Given this list of marker genes H2-Eb1, Tgm2, Malt1, Il18, Arid2, Agr2, Hacd1, Cd1d1, Epha7 (Eph receptor A7), Has2, Pycard, Smarcd2, C2cd4a, Src, Tnc, Rc3h2, Xcl1, Zfp608, Cd86, Sema3e, Pdgfb, Iqgap1, Nlrp3, Trpv4, Slc7a1, Glmn, Gpam (NCBI Gene Id 14732), Prex1, Ccl2, Dusp10, Ctla4, Icos, Ihh, Dscam, Kitl, Itga3, Tnf, Gstp1, Bad, H2-Ob, Nfkbiz, Serpine1, Cx3cl1, Hspd1, Dnm2, Ap1ar, Adamts18, Dll1, Nkap, Kng1, Dbn1, Il1rl2, Il3, Spaca7, Chst2, Cd3e, Plxnc1, Selenok, Cd4, Itpkb, Jag1 (jagged 1), Ptpn23, Cd44, Zc3h12d, Wnt1, Ptpn1, Ptpn11, Htr2a, Cebpb (NCBI Gene Id 18031), Cbfb, Plxnb1, Foxo3, Plxnb2, Tgfb2 (NCBI Gene Id 98738), Slk, Clasp1, Rin2, Igfbp2, Myadm, Cd209e, Tesc, Spta1 (NCBI Gene Id 98361), Col8a1, Mir326, Pag1, Npy2r, Fbxo38, Mad2l2, Ctsg, Hspg2, Cdkn2a, Ccn1, Itgal, Mia3, Ccl21f, Srf, Fcho1, Ceacam1, Actg1, Tescl, Prkcq, Rbpj, Peli1, Tnxb, Vav3, Sema4d, Il6, Kdr, Ccl21e, Cxcr4, Taok2, Acp5, H2-Eb2, Cspg5, Meltf, Dysf, Cldn7, Edil3, Spi1, Prkcd, Efnb2, Atp5f1b, Muc21, Tmx1, Smarcd3, Cask, Tsc2, Rnase10, Kif14, Vps33b, Lilrb4a, Sema5a, Nf2, Shh, Apod, Il23a, Fgg, Apoa1, Rras, Map2k1, Cd27, Cyrib, Ccl21a, Hlx, Pik3r2, Pik3cb, Lrrc32, Lrfn3, Dsg2, Fadd, Angpt1, St3gal4, Lamc1, Adam9, Epha8, Ephb2, Atm, Fbln2, Shb, Jag2, Dhps, Fn1, Btnl2, Pdcd1, Tnr, Il21, Il12a, Coro1c, Casp3, Cdh1, Dab1, Lama4, Sox13, Bag4, Col16a1 (collagen, type XVI, alpha 1), Ank3, Plxnb3, Nat8f2, Akna, C2cd4b, Men1, Foxf1, H2-Aa, Capn1, Kifap3, Tespa1, Nat8f5, Ccl25, Rps3, Gcnt1, Smad3, Prkaa1, Npnt, Plet1, Itch, Csf1, Phldb2, Ppp1cb, Sema6a, Carmil2, Utrn, Clec4g, Rasa1, Emp2, Traf6, Flot1, Rac3, Cd24a, Spock2, Adgrg1, Rela, Slfn1, Il1b, Wnt4, Notch4, Fut2, Cd80, Mdga2, Ift74, Zdhhc2, Loxl3, Stat5a, Gp1ba, Coro1a, Ambra1, Vwc2, Smad7, Nodal, Ptk2b, Abl1, Nat8, Lgals9, Mad1l1, Nfkbid, Vcam1, Cbll1, Dtx1, Col1a1, Cxcl13, Serpine2, Ceacam2, Adk, Bmp6, Tnfrsf21 (tumor necrosis factor receptor superfamily, member 21), Arl2, Prkar1a, Dag1, Rag2 (recombination activating gene 2), Piezo1, Ilk, Pde3b, Spg7, Bmi1, Actl6a, Dlg5, Nuak1, Ywhag, Srcin1, Podxl, Rac1, P4hb, Foxp3 (NCBI Gene Id 20371), Erbb2, Ufl1, Ripor2, Tnfrsf13c, Jam3, Wnt10b, Gnrh1, Mdk, B2m, Pawr, Cyth3, Zc3h8, Mmrn1, Brd2, Abi3bp, Dennd6a, Jak2, Ccl5 (NCBI Gene Id 20304), Ephb3, Havcr2, Slamf1, Cd55, Ndnf, Cd5, Icosl, Arpc2, Smoc1, Nck1, Plxnd1, Card11, Erbb3, Itgb3, Nrp1, Lgals1, Sh2b3, Swap70, Fzd7, Pnp, Efnb1, Gpr4, Smarcc1, Epha1, Ddr1, Nedd9, Vsir, Dusp3, Rag1, Cd274 (CD274 antigen), Peak1, Lamb2, Nf1, Bmp7, Ptprc, Dact2, Dapk3, Il2ra, Tigit, Tesk1, Cd55b, Ptprz1, Flna, Ptpru, Pde4d, Snai2, Fbln1, Mdga1, Ptk2, Pdpn, Nrarp, Myo1f, Tnfsf13b, Tnn, Dock8, Epo, Fes, Elane, Cd40lg, Wdpcp, Ccm2l, Cd59a, Nckap1l, Pten, Il15, Arg1, Triobp, Chrd, Bmp4, Acvrl1, Pla2g2a, Ythdf2, Rc3h1, Lyn, Ptpn2, Itgb2, Lims1, Prnp, Adam10, Defb21, Il36b, Gata3, Cd74, Celsr2, Pla2g2f, Fam107a, Il2 (NCBI Gene Id 16183), Fga, Ep300, Cd9 (NCBI Gene Id 12527), Prkcz, Angpt2, Jak3, Lpxn, Irf1, Hrg, Lims2, Plpp3, Cxcl12, Fzd4, Itga4, Socs6, Dmtn, Sdc4, Efna5, Lgals3, Dicer1, Ninj1, Muc4, Prkg1, Cfl1, Ccr2, Hoxa7, Sox12, Fermt1, Thbs1, Ptn, Stk4, Adam15, Cav1, Ido1, C1qtnf1, Smarcc2, Dusp1, Dlc1, H2-Oa, Plau, Bcar1, Pkd1, Ldb1, Coro2b, Gfus, Prdx2, Myo10, Cd244a, Ppp3ca, Mink1, Anxa1, Smarcb1, Cd83, Lgals8, Map2k5, Hsp90aa1, Rgcc, Ets1, Tjp1, Phf10, Pck1, Lag3, Itga5, Hes1, Pik3r6, H2-M3, Tyk2, Vav1, Ptprj, Ripk2, Cd6, Dab2, Ifnb1, Ptpn6, Acer2 (NCBI Gene Id 73682), Dock5, Crtam, Smarcd1, Chst4, Plaur, Itgb1, Postn, Pdcd1lg2, Cd63, Calca, Ephb4, Epha3, S100a10, Pcsk5, Zbtb7b, Prkca, Sftpd, Smarce1, Mbp, Dusp26, Hfe, Cyld, Cytip, Il7r, Ibsp, Cdh13, Skint1, Scrib, Rock1, Nfat5, B4galnt2, Igf2, Twsg1, Tbx18, Rap1gap, Sele (selectin, endothelial cell), Il7, Grem1, Il20rb, Ndfip1, Epha4, Clasp2, Cd209d, Alox15 (arachidonate 15-lipoxygenase), Epha5, Smoc2, Sash3, Emilin1, Emcn, Efnb3, Actl6b, Bmp2, Gpnmb, Nr4a3, Lep, Zfp35, Ptpra, Prkx, Il4, Lif, Nat8f3, Ccdc80, Arid1a, Myoc, Nid1, Ccr7, Cited2, Cd1d2, Scgb1a1, Notch1, Nrg1, Btla, Il2rg, Onecut1, Abca12, Dmd, Btn2a2, Flot2, Sox2, Map4k4, Skap1, Il4ra, Ppm1f, Limch1, Ccr5, Bcl2, Onecut2, Pkp2, Ephb6, Zfp703, H2-T23, Dmp1, Spint2, Zmiz1, Tbcd, Il6ra, Tnfsf9, Nr5a2, Epb41l5 (erythrocyte membrane protein band 4.1 like 5), Mettl3, Macf1, Runx1, Akt1, Tnfsf11, Stx3, Spp1, Thy1, Adipoq, Ppara, Nat8f1, Sox9, Megf10, Cass4 (Cas scaffolding protein family member 4), Tfrc, Dpp4, Ajap1, Vcl, Pkp1, Tnfsf18, Slc4a1, Nexmif, Disc1, Il1a, Ptafr, Dlg1 (NCBI Gene Id 320792), Ccl21d, Smarca2, Marchf7, Prkce, Tmem131l, Rac2, Egflam, Gimap5, Unc13d, Cd276, Efemp2, Myh9, Ubash3b, Pde5a, Ccl19 (C-C motif chemokine ligand 19), Klhl22, H2-DMa, Socs1, Lama3, Ccl28, Fut7, Crkl, Ass1, Afdn, Il1rn, Ret, Cd28, Dscaml1, Col26a1, Stat5b, Plg, Irak1, Fut9, Calr, Klhl25, Bcl6, Fut4, Spink5, Zdhhc21, Itga2, Pla2g2d, Cd36, Stx4a, Mfsd2b, Muc1, Foxj1, Rell2, Rasal3, Lama5, Mmp12, Tsc1, Rdx, Socs5, Vtn, St6gal1, Tnfsf4, Brd7, Fmn1, Spn, Cdk6, Klf4, Wnk1, Camsap3, Ifng, Npy, Laptm5, Dnaja3, Mmp2, Zp3, Dock1, Rsu1, Carmil1, Rreb1, Emilin2, Ptpn22, Myf5, Gpm6b, Syk, Tnfsf14, Magi2, Pld2, Tnfrsf18, Hsph1 (NCBI Gene Id 15505), Kank1, Ascl2, Ptger4, Sirpa, Opa1, Ap3d1, Cd69, Tnfaip8l2, Gli3, Cripto, Itgav, F11r, Xbp1 (X-box binding protein 1), Faf1, Alox5, Itga6, Bst1, Zc3h12a, Zfhx3, Cd160 (CD160 antigen), Arg2 (arginase type II), Alox12, Brd4, Il12rb1, H2-Ab1, Cd81, Tpm1, Tspan32, Tbx21, Ccdc88b, Pkhd1, Mmp14, Prlr, Spock1, Il4i1, Rara, H2-DMb2, Pml (NCBI Gene Id 338524), Ap3b1, Rnd1, Trem1, Tenm3, Tnfrsf14 (tumor necrosis factor receptor superfamily, member 14 (herpesvirus entry mediator)), Hyal1, Fgl2, Jam2 (NCBI Gene Id 76825), Cd47, Tgfb1, Fgl1, Ccl21b, Wnt5a, Sfn, Efna1, Cyth2, Spry4, Vit, Runx3, Wnt3a, Cdsn, Zap70, Pbrm1, Lef1, Adora2a, Vegfa, Adam8, Epha2, Hspb1, Lax1, Gsk3b, Vsig4, Crk, Ppp1r12a, Cd300a, Dapl1, Rhoa, Cd209c, Selp, Braf, Egr3, Lck, Cela2a (NCBI Gene Id 13706), Atxn3, Tnfaip3, Rhod, Blm, Dusp22, Mapk14, Adam19, Actb, Tfe3, Plekha2, Fstl3, Irgm1, Tarm1, Lama2, Magi1, Cxcr3, L1cam, Icam1, Fermt3, Kif26b, Olfm4 (NCBI Gene Id 380924), Kat5, Actn4, Pkp3, Lilrb4b, Mex3b, Cdc42, Slc4a2, C1qbp, Zfp609, Il12b, Igf1, Ildr2, Fut1, Nck2, Bcl10, Tek, Adtrp, Fermt2, Rasgrp1, Arhgap6, Aif1, Cyp1b1, Sec1, Lamb1, Cd37, Gimap3, Smarca4, Tmem102, Egfl6, P2ry12, Gtpbp4, Kng2, Lama1, Prkd2 (NCBI Gene Id 232912), Pf4, Mip, Mapk7, Enpp2, Cd46, Cd59b, Jak1, Pcdh8, Itgb1bp1, Pla2g5 (phospholipase A2, group V), Rhoh, Fgb, Frmd5 (FERM domain containing 5), Specc1l (sperm antigen with calponin homology and coiled-coil domains 1-like), Epcam, Tgfbr2 (transforming growth factor, beta receptor II), Apc, Sox4, Abl2, Sart1, Zbtb1, Hmgb1, Ager, Vtcn1, Hsd17b12, Apbb1ip, Ada, Vnn1, Il6st, Epb41l4b, H2-Ea, Gcnt2, Cib1, Ecm2, Jup, Poldip2, H2-DMb1, Tacstd2, Rcc2, Pik3r1, S1pr1, Lrp1, Cblb, Foxc2, Il10, here is a description of the gene set: Mouse Gene Set: GOBP_REGULATION_OF_CELL_ADHESION Any process that modulates the frequency, rate or extent of attachment of a cell to another cell or to the extracellular matrix. studied in species Mus musculus